Given this list of marker genes HLA-C, ACRBP, EPSTI1, TUBB1, GP1BB, SH3BGRL2, MT-ATP8, CCL5, TSPAN33, MAP3K7CL, KLRD1, MT-ATP6, MT-CO3, MT-CYB (NCBI Gene Id 4519), DDX11L10, TRBC2, IFITM3, TREML1, MT-ND4L, GNLY, OASL, IFITM1, HLA-H, MT-ND1, PF4, MYL9, CCL4, MT-ND2, MYOM2, here is a description of the gene set: Background: Up to 30% of patients with pediatric inflammatory bowel disease (IBD) do not respond to anti-Tumor Necrosis Factor (anti-TNF) therapy. The aim of this study was to identify pharmacogenomic markers that predict early response to anti-TNF drugs in pediatric patients with IBD. Methods: An observational, longitudinal, prospective cohort study was conducted. The study population comprised 38 patients with IBD aged < 18 years who started treatment with infliximab or adalimumab (29 responders and nine non-responders). Whole gene expression profiles from total RNA isolated from whole blood samples of six responders and six non-responders taken before administration of the biologic and after two weeks of therapy were analyzed using next-generation RNA sequencing. The expression of six selected genes was measured for purposes of validation in all of the 38 patients recruited using qPCR. Results: Genes were differentially expressed in non-responders and responders (32 before initiation of treatment and 44 after two weeks, Log2FC (Fold change) >0.6 or <_0.6 and p value < 0.05). After validation, FCGR1A, FCGR1B, and GBP1 were overexpressed in non-responders two weeks after initiation of anti-TNF treatment (Log2FC 1.05, 1.21, and 1.08, respectively, p value < 0.05). Conclusion: Expression of the FCGR1A, FCGR1B, and GBP1 genes is a pharmacogenomic biomarker of early response to anti-TNF agents in pediatric IBD. species: Homo sapiens Genes upregulated in anti-TNF therapy non-responders vs. responders prior to the initiation of anti-TNF therapy from publication Salvador-Martín S, Kaczmarczyk B, Álvarez R, Navas-López VM, Gallego-Fernández C, Moreno-Álvarez A, Solar-Boga A, Sánchez C, Tolin M, Velasco M, Muñoz-Codoceo R, Rodriguez-Martinez A, Vayo CA, Bossacoma F, Pujol-Muncunill G, Fobelo MJ, Millán-Jiménez A, Magallares L, Martínez-Ojinaga E, Loverdos I, Eizaguirre FJ, Blanca-García JA, Clemente S, García-Romero R, Merino-Bohórquez V, González de Caldas R, Vázquez E, Dopazo A, Sanjurjo-Sáez M, López-Fernández LA (PMID 33429950) Human Gene Set: SALVADOR_MARTIN_PEDIATRIC_TBD_ANTI_TNF_THERAPY_NONRESPONDER_PRE_TREATMENT_UP